The following is a description of a gene set: from publication Berenjeno IM, Núñez F, Bustelo XR (PMID 17213802) Human Gene Set: BERENJENO_TRANSFORMED_BY_RHOA_REVERSIBLY_DN Genes down-regulated in NIH3T3 cells (fibroblasts) transformed by expression of contitutively active (Q63L) form of RHOA off plasmid vector; their expression reverted completely after treatment with Y27632, an inhibitor of ROCK proteins. We have used microarray technology to identify the transcriptional targets of Rho subfamily guanosine 5'-triphosphate (GTP)ases in NIH3T3 cells. This analysis indicated that murine fibroblasts transformed by these proteins show similar transcriptomal profiles. Functional annotation of the regulated genes indicate that Rho subfamily GTPases target a wide spectrum of functions, although loci encoding proteins linked to proliferation and DNA synthesis/transcription are upregulated preferentially. Rho proteins promote four main networks of interacting proteins nucleated around E2F, c-Jun, c-Myc and p53. Of those, E2F, c-Jun and c-Myc are essential for the maintenance of cell transformation. Inhibition of Rock, one of the main Rho GTPase targets, leads to small changes in the transcriptome of Rho-transformed cells. Rock inhibition decreases c-myc gene expression without affecting the E2F and c-Jun pathways. Loss-of-function studies demonstrate that c-Myc is important for the blockage of cell-contact inhibition rather than for promoting the proliferation of Rho-transformed cells. However, c-Myc overexpression does not bypass the inhibition of cell transformation induced by Rock blockage, indicating that c-Myc is essential, but not sufficient, for Rock-dependent transformation. These results reveal the complexity of the genetic program orchestrated by the Rho subfamily and pinpoint protein networks that mediate different aspects of the malignant phenotype of Rho-transformed cells. species: Mus musculus, and this is the list of marker genes: TNC, CINP, LY75, IRGM, PHLDB2, PBX3, CBX1, PTGER4, FHL1, THY1, ACTG2, ADM, AK4, SERPINE1, CCN1, SORBS1, ALCAM, CCN2, FEZ2, THBS1, ACTA1, ACTN4, DUSP6, LATS2, TAGLN, MYC, TMSB4X, INHBA, IGF2, ERRFI1